Given this list of marker genes Gp1ba, Clcn3, Dusp5, Tmem40, Castor1, Tmx1, Mfn1, Gaa, Smg1, Rhbdd3, Cog6, here is a description of the gene set: from publication Cui A, Huang T, Li S, Ma A, Pérez JL, Sander C, Keskin DB, Wu CJ, Fraenkel E, Hacohen N (PMID 38057668) Genes positively differentially expressed in cell type: Mast cell upon treatment with cytokine: FGF-β in mouse lymph nodes in vivo. Cytokines mediate cell-cell communication in the immune system and represent important therapeutic targets. A myriad of studies have highlighted their central role in immune function, yet we lack a global view of the cellular responses of each immune cell type to each cytokine. To address this gap, the authors created the Immune Dictionary, a compendium of single-cell transcriptomic profiles of more than 17 immune cell types in response to each of 86 cytokines (>1,400 cytokine-cell type combinations) in mouse lymph nodes in vivo. A cytokine-centric view of the dictionary revealed that most cytokines induce highly cell-type-specific responses. For example, the inflammatory cytokine interleukin-1β induces distinct gene programmes in almost every cell type. A cell-type-centric view of the dictionary identified more than 66 cytokine-driven cellular polarization states across immune cell types, including previously uncharacterized states such as an interleukin-18-induced polyfunctional natural killer cell state. species: Mus musculus Mouse Gene Set: CUI_MAST_CELL_FGF_BASIC_RESPONSE_UP